Given this list of marker genes DHCR7, TM7SF2, HSD17B7, LBR, SC5D, CYP51A1, MSMO1, EBP, DHCR24, NSDHL, here is a description of the gene set: Reactome Pathway: Cholesterol biosynthesis via desmosterol (Bloch pathway) The transformation of zymosterol into cholesterol can follow either of routes, one in which reduction of the double bond in the isooctyl side chain is the final step (cholesterol synthesis via desmosterol, also known as the Bloch pathway) and one in which this reduction is the first step (cholesterol biosynthesis via lathosterol, also known as the Kandutsch-Russell pathway). The former pathway is prominent in the liver and many other tissues while the latter is prominent in skin, where it may serve as the source of the 7-dehydrocholesterol that is the starting point for the synthesis of D vitamins. part of: Cholesterol biosynthesis species: Homo sapiens